Given this list of marker genes SCN9A, POLG, TYMP, SCN10A, SCN11A, here is a description of the gene set: Pain due to a stimulus that does not normally provoke pain. species: Homo sapiens Human Gene Set: HP_ALLODYNIA Allodynia